The following is a description of a gene set: species: Mus musculus Mouse Gene Set: GOBP_POSITIVE_REGULATION_OF_LIPID_TRANSPORT Any process that activates or increases the frequency, rate or extent of the directed movement of lipids into, out of or within a cell, or between cells, by means of some agent such as a transporter or pore., and this is the list of marker genes: Ldlrap1, Erfe, Prkcd, Ptch1, Lipg, Abcg4, Abca5, Fasl, Acsl6, Ptges, Lpcat3, Abca3, Bmp6, Dbi, Sirt1, Cyp4a31, Cyp19a1, Tmf1, Ces1e, Tac1, Nucb2, Commd1, Ecrg4, Tmem30a, Nfkb1, Pon1, Ces1a, Atp8a2, Runx1, Edn1, Map2k6, Gal, Tnfrsf11a, Il1a, Abcb4, Pla2g3, Cyp4a10, Adipoq, Lrat, Fabp3, Pla2g4a, Washc1, Nmb, Anxa2, Apoa1, Nfkbia, Pla2r1, C1qtnf1, Nr1h3, Mif, Ces1c, Lrp1, Dennd5b, Prap1, Xrcc4, Abca1, Abca8b, Acsl1, Prelid1, Abca13, Myb, Eepd1, Mfn2, Pla2g6, Nkx3-1, Crh, Pltp, Ghrl, Mapk9, Ntsr1, Hrh3, Abcg1, Oxt, Avpr1b, Tnfsf11, Ces1h, Gps2, Ces1f, Pla2g10, Scp2, Ces1g, Sstr4, P2rx7, Abca7, Dab2, Abca8a, Cav1, Triap1, Zdhhc8, Pparg, Abca12, Cyp4a32, Galr1, P2ry2, Atp8a1, Spp1, Trem2, Il1b, Apoe, Ces1d, Retn, Nr1h2, Acsl5, Ces1b, Cyp2j5